Given this list of marker genes Vangl2, Jam3, Nckap1, Rdx, Actb, Insc, Shroom2, Celsr1, Rab14, Arf4, Dlg5, Napa (N-ethylmaleimide sensitive fusion protein attachment protein alpha), Shroom3, Atp8b1, Hcn1, here is a description of the gene set: Mouse Gene Set: GOBP_APICAL_PROTEIN_LOCALIZATION studied in species Mus musculus Any process in which a protein is transported to, or maintained in, apical regions of the cell.